The following is a description of a gene set: Catalysis of the reaction: S-adenosyl-L-methionine + histone H4 L-lysine (position 12) = S-adenosyl-L-homocysteine + histone H4 N6-methyl-L-lysine (position 12). This reaction is the addition of a methyl group to the lysine residue at position 12 of the histone H4 protein. Mouse Gene Set: GOMF_HISTONE_H4K12_METHYLTRANSFERASE_ACTIVITY studied in species Mus musculus, and this is the list of marker genes: Prmt2, N6amt1, Prmt8, Prmt9, Carm1, Prmt1, Ndufaf7, Prmt6 (NCBI Gene Id 99955), Prmt5 (NCBI Gene Id 27374)